Given this list of marker genes Arpc1b (actin related protein 2/3 complex, subunit 1B), Polr2a, Pld3, Txn2, Mgp (NCBI Gene Id 223886), Csf2ra, Gga3, P2ry12 (purinergic receptor P2Y, G-protein coupled 12), Etv1, Tmsb10, Sdhc, Arhgdia, Rab35, Ms4a7, Arpc3, Ubb-ps, Cd47, Map1lc3b, Dync1i2, Rnf44, Col1a2, Olfml3, Plp1, Plxdc2, Tmem160, Sparc, Ywhae, Capzb, Shisa5, Pomp, Fkbp5 (NCBI Gene Id 52022), Tpcn1 (two pore channel 1), Dcn, Ifitm2, Alox5ap, Cfl1, Rpl6, Tle5 (NCBI Gene Id 14797), Gsn (NCBI Gene Id 227753), Cyba, Rps3, Lum (NCBI Gene Id 17022), Lat2, Spi1, Cotl1, Psmb8, Atp5f1c, Tmem119, Slco2b1, Rpl13a, here is a description of the gene set: from publication Tabula Muris Consortium (PMID 32669714) Mouse Gene Set: TABULA_MURIS_SENIS_BRAIN_MYELOID_MACROPHAGE_AGEING studied in species Mus musculus